The following is a description of a gene set: Mouse Gene Set: GOMF_DNA_BINDING_BENDING The activity of binding selectively and non-covalently to and distorting the original structure of DNA, typically a straight helix, into a bend, or increasing the bend if the original structure was intrinsically bent due to its sequence. studied in species Mus musculus, and this is the list of marker genes: Hmgb2, Cebpg, Hmgb4, Lef1, Top2a, Foxc1, Foxd1, Hmga2, Hmga1, Terf1, Hmga1b, Sry, Trex1, Top1, Tfam, Hhex, Hmgb3 (NCBI Gene Id 15355), Sap30l, Hmgb1